Given this list of marker genes LPIN2, CHKB, ETNPPL, PCYT2, PHOSPHO1, LPIN1, LPIN3, ETNK2, ETNK1, CEPT1, SELENOI, PISD, CHKA, here is a description of the gene set: <i>De novo</i> (Kennedy pathway) synthesis of phosphatidylethanolamine (PE) involves phosphorylation of ethanolamine (ETA) to phosphoethanolamine (PETA) followed by condensing with cytidine triphosphate (CTP) to form CDP-ethanolamine (CDP-ETA). Diacylglycerol (DAG) and CDP-ETA together then form PE. Alternatively, PE is formed when phosphatidylserine (PS) is decarboxylated by phosphatidylserine decarboxylase proenzyme (PISD). species: Homo sapiens Reactome Pathway: Synthesis of PE part of: Glycerophospholipid biosynthesis